Given this list of marker genes Ptgs1, Hbb-bt (hemoglobin, beta adult t chain), Ltc4s, Pxdn, Gpx6, Prdx5, Mpo, Gstp2, Alox5ap, Mgst1, Gpx1, Gstt2, Hbb-bs, Gstk1, Txndc17, Mgst3, Gstp3, Selenof (NCBI Gene Id 93684), Prdx3, Cat, Epx, Ptges, Gsta1, Hba-a2, Tpo, Mb, Sesn1, Prdx2, Gpx2, Gpx8, Prxl2b, Gsta5, Prdx6b, Prdx6, Ptgs2, Lpo, Hbb-bh2, Hbb-bh1 (hemoglobin Z, beta-like embryonic chain), Txnrd1, Lrrk2, Sesn2, Gstp-ps, Gpx5, Cygb, Gsta13, Cp, Hba-x, Prdx1 (NCBI Gene Id 18477), Hbb-y, Prdx4, Hbb-bh0, Gsta2, Gpx3, Upk3bl, Gstm7, Park7, Hba-a1, Gpx7, Gstt1, Hbq1b, Mgst2, Gstp1, Gpx4, Hbq1a, Sesn3, here is a description of the gene set: Mouse Gene Set: GOMF_OXIDOREDUCTASE_ACTIVITY_ACTING_ON_PEROXIDE_AS_ACCEPTOR Catalysis of an oxidation-reduction (redox) reaction in which the peroxide group acts as a hydrogen or electron acceptor. studied in species Mus musculus